The following is a description of a gene set: Human Gene Set: CEBP_Q3 Genes having at least one occurrence of the motif NNNTKNNGNAAN in the regions spanning 4 kb centered on their transcription starting sites. This matches the CEBPA transcription factor binding site V$CEBP_Q3 (v7.4 TRANSFAC). species: Homo sapiens, and this is the list of marker genes: AGER, LRRFIP2, DYRK3, SLC25A35, SNCAIP, SUPT3H, CFL2, GPLD1 (NCBI Gene Id 2822), EFNA5 (ephrin A5), ID3, PTEN, PRKCG (protein kinase C gamma), CITED4, MAOA, SLC44A4, NDUFA4L2, RARB, ELAVL4, CCDC91, PER3, NCKAP5, NCAM1, MAP3K20, CRH, RS1, RASSF8, CHMP1B (charged multivesicular body protein 1B), PUM2, TOB1, STK33, HMGN3, TBL1Y, MYH4, ZNF470, KRTAP11-1, EDNRA, TBX5, SYNE2, UBXN10, JUN, PIGP, IL1RAPL1, TRMT10A, ASAH2, SS18, PALLD, GPC4, GYS1, TRPM1, DDIT4L, SPTLC2, PDGFB, CCN1 (cellular communication network factor 1), HMGN2, DOCK8, NFE2L2, PCDHA11, HOXA5, PAX8, HS6ST2, NAT9, THRA, FBXW7, SLC12A1, MOSPD2, SOBP, KCNJ13 (potassium inwardly rectifying channel subfamily J member 13), LRRTM3, FAM91A1, CCL8, NR2F2, PURA, SERPINA7, SEPTIN9, CALR, LEMD2, LINC03122, C1QTNF4, KAT7, HOXD10, ERBB2, PLS1, SPAG9, RUVBL2 (RuvB like AAA ATPase 2), CTAGE1, TLR8, NPVF, OPN1LW, RORA, NAB1, CLTC, GSTA4, MID1, DMD, TBL1X, SPOP, RNF17, ZNF28, TRPS1, PDRG1, NFATC4, BCL11B, FAM53B (family with sequence similarity 53 member B), PALS2, NNAT, CALD1, ASCL2, PPM1E, CHIC2, TMEM268, UBXN1, MN1, CNTLN, ZNF818P, PLAC1, SPIB, MARCHF1, CAPZA2, KIF2B, SFSWAP, MSRB1, ANP32A, BDNF, CCDC138, PBDC1, NUP155, CD55, IL19, MIDEAS, MIA2, HOXC6, PRKAG1, WNT10B, ANKS1B, PAX7, HNRNPR, TMEM71, FOXP2, KPNA3 (NCBI Gene Id 3839), MAP2K3, TGFB2, TNFSF10, PTGR3, ALB, CD200R1, PDGFRB, ARHGEF38, SSR1, ZNF654, RGS18, ZBTB20, ALDH5A1, MYH8 (NCBI Gene Id 4626), ZBED5, JUNB, RGS22, MXI1, ALDH1A2, XKRX, CCR3, TIMM8A, SUV39H1, CADM1, FOXP3, FIGN, NFKBIZ, PCGF1, WNT3, WNT5A, GNAO1, ARNT, RRBP1, CBX4, LPAR4, PRG4, MYL3, HOXC4, MAP2K6, SIRPA, TAGAP, WNK1, SEPTIN14, TNNC2, KITLG, NR0B2, C2CD5, ONECUT2, POU3F4, S100G, RAB30, ZNF428, EIF4A2, MNT, HTR2C, ETV5, OFCC1, LMO4, SLC36A2 (NCBI Gene Id 153201), MYH1, ACSL5, TCF12, PLA2G4A, SPRED1, BCL11A, NRXN3, SOX1, MAP3K3, SFMBT1, PLCB2, SLC35G2, HERC4, AQP9, IRX5, BCL6, SYNCRIP, PITX2, UBE2E2, DLG2, CEP120, ATOH1, PBXIP1, PHOX2B, USP9X, RAB3IP, SHKBP1, MED13, HHIP, GJA3, TFAP2D, LCOR, FOXN3 (NCBI Gene Id 654111), USP34, ZNF462, ADAMTS2, NEUROG1, CDK16, DDIT3, SNX12 (sorting nexin 12), RHOB, MEIS2, NSUN6, JARID2, TBR1, TMEM104, LIPG, CADM2 (NCBI Gene Id 253559), S100PBP, TSPAN7, TMEM126B (NCBI Gene Id 95018), PCTP, BRD2, TMEM88, NUDT18, DGKH, OVOL2, MMP27